Given this list of marker genes ATP1B4, YWHAB, PFDN1, TMEM260, JADE2, PPP1R26, CPLX1, SLC35C2, EFCAB11, STXBP3, USP31, TMEM132E, CNTN2, VPS53, CDH18, DTNA, GPSM1, PTPRT, YWHAG, BAIAP2L1, KCTD18, RALBP1, RRAS2, EVC (NCBI Gene Id 7886), THUMPD1, SYT15, SPRN, KCNIP3 (potassium voltage-gated channel interacting protein 3), KIF2A, SLC22A23, CLEC1A, BSN, TPCN1, SULT4A1, ASF1B, NDST1, LAMC1, TUBGCP4, PCTP, HEYL, CARHSP1, SESTD1, PAX8, PTPRJ (NCBI Gene Id 5795), ZNF747, AKAP10, PPIE, MEA1, TRIM66, GATAD2B, OGT, CGNL1, PTPRF, TFAM, ARFIP2, GRIN3A, DDAH1, MSI2, PACRGL, NPTX1, SLC35E2A, GNAO1, UBE4B (NCBI Gene Id 10277), TTC28, CLSPN, UBXN2B, MAP7D1, MOGAT2, USP54, PLPP6, TRARG1, P2RX2, FOXP3, CRACDL, SLC6A15 (NCBI Gene Id 59276), EHMT1, TEDDM1, RHOF, RNLS, ATF7, CREB3L3, NRN1, SMPD1, ZZZ3, SEPTIN10, SLC35E2B, TM4SF18, RABL3, ZSWIM6, GRIN2B, here is a description of the gene set: Genes predicted to be targets of miRBase v22 microRNA hsa-miR-7974 in miRDB v6.0 with MirTarget v4 prediction scores > 80 (high confidence targets). Human Gene Set: MIR7974 species: Homo sapiens from publication Chen Y, Wang X (PMID 31504780)